Given this list of marker genes Csnk2b, Adipor1, Adipoq, Appl1 (adaptor protein, phosphotyrosine interaction, PH domain and leucine zipper containing 1), Appl2, Slc27a1, Adipor2, Acsl1, here is a description of the gene set: The series of molecular signals initiated by adiponectin binding to its receptor on the surface of a cell, and ending with the regulation of a downstream cellular process, e.g. transcription. Mouse Gene Set: GOBP_ADIPONECTIN_ACTIVATED_SIGNALING_PATHWAY studied in species Mus musculus